The following is a description of a gene set: Human Gene Set: HP_CUTANEOUS_SYNDACTYLY_OF_TOES species: Homo sapiens A soft tissue continuity in the anteroposterior axis between adjacent foot digits that involves at least half of the proximodistal length of one of the two involved digits; or, a soft tissue continuity in the A/P axis between two digits of the foot that does not meet the prior objective criteria. Cutaneous syndactyly of toes, and this is the list of marker genes: GJA1, DHCR7, MCTP2, GLI3, EP300, FGF16, SMOC1, CREBBP, NOG, SLC39A8, PRKD1, GABRA3, CAMTA1 (NCBI Gene Id 23261), DYRK1A, TRRAP, MECP2, SVBP, FAT4, MYH8, RPL10, NECTIN1, BCOR, TP63, CACNA1C, MAP3K20, SMARCAD1, FGF9, SCARF2 (scavenger receptor class F member 2), SC5D, NECTIN4, ATP9A, FGFR2, FGFR1, EBF3, DEAF1, IQCE